The following is a description of a gene set: Mouse Gene Set: GOBP_ORGANIC_ACID_TRANSMEMBRANE_TRANSPORT studied in species Mus musculus The process in which an organic acid is transported across a membrane., and this is the list of marker genes: Acsl1, Mpc1, Acacb, Acsl6, Slc16a12, Slc19a1, Slc1a3, Slc25a10, Slc38a9, Cln3, Slc5a6, Slc1a2, Sfxn1, Slc25a22, Slc43a1, Slc43a2, Cltrn, Slc16a8 (NCBI Gene Id 57274), Ntsr1, Slc13a3, Abcd1, Slc6a5, Lrp2, Slc25a12, Epm2a, Slc27a5, Slc5a8, Slc17a5, Arl6ip1, Slc3a2, Slc7a2, Tspo2, Mpc2, Slc25a2, Sfxn2, Slc5a12, Cpt1b, Slc16a9, Slc16a14, Slc6a20b, Itgb1, Arhgef11, Slc38a4, Slc7a7, Slc23a2, Septin2, Slc17a6, Myc, Slc16a3, Psen1, Mfsd12, Slc6a13, Slc25a38, Slc46a1, Slc2a1, Slc35d1, Slc38a1, Abcb1b, Slc7a10, Slc6a7, Cd36, Slc47a1, Slc23a1, Slc36a2, Slc25a18, Ttyh3, Slc25a1, Slc1a1, Slc16a1, Gfap, Slc7a6, Slc15a4, Abcd2, Slc6a8 (NCBI Gene Id 12911), Slc7a14, Slc6a14, Arg1, Kcnj10, Irs2, Lrrc8a, Slc6a20a, Prkcd, Slc38a6, Ctns, Slc25a20 (NCBI Gene Id 97527), Per2, Slc66a1, Arg2, Slc7a13, Slc25a15, Cpt2, Slc36a1, Agt, Slc3a1, Ttyh2, Cln8, Selenon, Slc1a4, Slc17a8, Slc16a7, Rgs4, Nat3, Acsl5, Abcb1a, Slc7a11, Slc6a15, Slc26a7, Slc7a4, Tnf, Slc25a26, Abcd3, Slc25a21, Slc7a3, Ucp2, Slc38a5, Slc13a2, Lrrc8e, Slc25a32, Slc6a11, Slc6a9, Slc36a3, Slc38a2 (NCBI Gene Id 67760), Abcd4, Slc25a13, Nfkbie, Ttyh1, Grik1, Slc6a6, Slc7a1, Slc16a11, Slc11a1, Abcc1, Slc25a29, Slc16a4, Slc22a2, Arl6ip5, Emb, Grm1, Ace2, Lrrc8d, Slc7a5, Slc25a11, Slc7a8, Slc1a5, Thbs1, Slc1a7, Sfxn3 (NCBI Gene Id 94280), Akt2, Slc1a6, Slc13a5, Slc27a1, Slc29a4, Akt1, Slc16a6, Abcc5, Rgs2, Slc38a3, Lrrc8b, Lrrc8c, Slc17a7